Given this list of marker genes IFI16 (NCBI Gene Id 3428), NUPR1, PIDD1, TAF9, TRIAP1, HIPK2, DVL2, ERCC2, E2F2, SNAI2, TIFAB, E2F7, HAPSTR1, TAF1, USP10, PAXIP1, MYC, RPS27L, AEN, USP7, NBN, MIF, USP2, TP53BP2, SGK1, HIPK4, FOXO3, PIP4P1 (phosphatidylinositol-4,5-bisphosphate 4-phosphatase 1), E2F1, DYRK1A, KDM1A, PHLDA3, RRN3, MAPKAPK5, ACER2, MDM2, JMY, DDIT4, BAX, CHD5, MYO6, PPP1R15A, BCL2L12, NOP2, TMEM109, ANKRD1, HIC1, MARCHF7, NDRG1, ARMC10, GML, CASP2, KMT5A, PSMD10, RBM38, RFFL, COPS3, KDM8, TP53BP1, PMAIP1, RPS20, PLK2, AKT1, RPL37, NPM1, CDK5RAP3 (CDK5 regulatory subunit associated protein 3), PYHIN1, SMARCA4, MLF1 (myeloid leukemia factor 1), EDA2R, BBC3, RPS7, CD44, STK11, RPF2, PPM1D, PLK3, DDX5, YJU2, CRADD, CD74, PTTG1IP, PYCARD, MIR186, TWIST1, RPL23, MIR21, BAG6, MLXIPL, EP300, FHIT, AARS1, TP73, CDKN2A, MAP2K6, RPS15, PLA2R1, RPL26, AURKB, CASP6, MDM4, PRAP1 (proline rich acidic protein 1), SIRT1, NUAK1, BATF, CHEK1, TOPORS, PPP2R5C, ZNF385B, CDKN1A, POU4F1, PRKN, MUC1, HINT1, URB2, TAF3, NDUFS6, MAGEA2B, USP15, SNW1, PML, RRM2B, SP100, PAK1IP1, RPL11 (ribosomal protein L11), MTOR, SHISA5, ELL3, WWOX, EEF1E1, ZNHIT1, ATR, TP63, SETD9, ING2, HEXIM1, CDIP1, POU4F2, FOXM1, BDKRB2, CDKN1B, RRP8, SNAI1, CSNK2A1, CHEK2, SMYD2, ZMPSTE24, HIPK1, ATAD5, RPS6KA6, BOK, HNRNPK, ATRX, PRMT5, BOP1, GREM1, EIF5A, KAT6A (NCBI Gene Id 7994), RPL5, TFAP4, TP53RK, ATM, KAT5, PRMT6, TRIM24, PDK2, TAF9B, TP53, DYRK2, ZNF385A, BRCA2, UBB, USP28, MSX1, BCL2, ING4, MSH2, NOP53, GTSE1, BCL3, AURKA, SOX4, MAGEA2, URI1, SPRED1, MYBBP1A, MORN3, SESN2, RRS1, RNF34, PERP, PPP1R13B, SPRED2, DYRK3, here is a description of the gene set: Human Gene Set: GOBP_SIGNAL_TRANSDUCTION_BY_P53_CLASS_MEDIATOR studied in species Homo sapiens An intracellular signaling process that is induced by the cell cycle regulator phosphoprotein p53 or an equivalent protein.